Given this list of marker genes IGF2, CDC37, KRT18, HBE1, SDCBP, WSB1, SRP72, VHL, CISH, TSC22D3, CLCN7, LYN, BMAL1, JUN, SDC4, GATA2, OSBPL8, SBNO1, SRSF11, DYNC1LI2, RBBP6, BMI1, SERPINB9, FCGRT, GLRX, DCT (dopachrome tautomerase), MAN2A2, JUNB, FXR1, TPR, CD36, MYC, here is a description of the gene set: Hematopoietic defects in HOXA9(-/-) mice demonstrate a key role for this homeoprotein in blood cell development. Conversely, enforced HOXA9 expression is leukemogenic in mice, and HOXA9 is frequently activated in human acute myeloid leukemia (AML). Although HOXA9 is thought to function as a transcription factor, few downstream targets have been identified. We searched for early HOXA9 target genes by using a transient overexpression strategy in 3 hematopoietic cell lines (2 myeloid, 1 lymphoid). cDNA microarray analyses identified genes whose expression was modulated at least 2-fold. Expression signatures in myeloid and lymphoid cells demonstrated that HOXA9 functions as both an activator and repressor of a variety of genes in cell-specific patterns suggesting that the transcriptional effects of HOXA9 are largely dependent on the cell context. Transient transcription assays and target gene expression patterns in HOXA9(-/-) marrow cells imply that we have identified direct physiologic targets. Many target genes are expressed in CD34+ stem cells or are members of gene families involved in proliferation or myeloid differentiation. Expression of 14 HOXA9 target genes correlated with high-level HOXA9 expression in primary AML. These data suggest that many genes identified in this survey may mediate the biologic effects of HOXA9 in normal and leukemic hematopoiesis. HOXA9 targets down-regulated in hematopoietic stem cells. from publication Dorsam ST, Ferrell CM, Dorsam GP, Derynck MK, Vijapurkar U, Khodabakhsh D, Pau B, Bernstein H, Haqq CM, Largman C, Lawrence HJ (PMID 14604967) Human Gene Set: DORSAM_HOXA9_TARGETS_DN studied in species Homo sapiens